Given this list of marker genes HGF, CSF1R, FGF16, FGF7, INS, FGF6, TGFA, FGF20, FGF4, EFNA2, FGFR1, FGFR2, BRAF, KDR, FGF18, VEGFA, EFNA3, GRB2, MAPK1, SOS1, PDGFRB, ANGPT4, MAP2K2, ERBB3, VEGFB, INSR (insulin receptor), EGFR, NRTN, NTRK1, PSPN, HRAS, KRAS, GDNF, CSF1, NTF3, IGF2, FGF9, ARTN (artemin), VEGFD, ANGPT2, TEK, VEGFC, FGF21, FLT3LG, MAP2K1, FGFR4, MAPK3, FGF19, FGF10, BDNF, MET, EFNA4, FGF1, EPHA2, FGF17, FGF3, NGFR, EFNA5, ARAF, EGF, FLT3, PGF, AREG, FLT4, FGF22, IGF1R, PDGFD, KIT, NRAS, KITLG, IGF1, EREG (epiregulin), NTF4, NTRK2, ANGPT1, RET, RAF1, FGF8, PDGFC, FLT1, FGF5, PDGFA, PDGFRA, ERBB4, EFNA1, ERBB2 (erb-b2 receptor tyrosine kinase 2), PDGFB, FGF23, FGF2, FGFR3, NGF, SOS2, here is a description of the gene set: studied in species Homo sapiens Human Gene Set: KEGG_MEDICUS_REFERENCE_GF_RTK_RAS_ERK_SIGNALING_PATHWAY GF-RTK-RAS-ERK signaling pathway. Pathway ID: N01592. Pathway type: Reference. Pathway class: nt06526 MAPK signaling. Pathway Definition from KEGG: GF -> RTK -> GRB2 -> SOS -> RAS -> RAF -> MEK -> ERK